The following is a description of a gene set: Any process that activates or increases the frequency, rate, or extent of myeloid cell apoptotic process. studied in species Mus musculus Mouse Gene Set: GOBP_POSITIVE_REGULATION_OF_MYELOID_CELL_APOPTOTIC_PROCESS, and this is the list of marker genes: Hcar2, Trim35, Nf1, Cd44, Pik3cb, Mef2c, Adipoq (adiponectin, C1Q and collagen domain containing), Cdkn2a, Sirt1, Pik3cd, Anxa1